Given this list of marker genes Tgfb1, Ccn2, Angpt2, Pdgfa, Igf1, Ptgs2 (prostaglandin-endoperoxide synthase 2), Hgf, Angpt1, here is a description of the gene set: from publication Galiè M, Konstantinidou G, Peroni D, Scambi I, Marchini C, Lisi V, Krampera M, Magnani P, Merigo F, Montani M, Boschi F, Marzola P, Orrù R, Farace P, Sbarbati A, Amici A (PMID 17998939) Tumor microenvironment in carcinomas recruits mesenchymal cells with an abnormal proangiogenic and invasive phenotype. It is not clear whether mesenchymal tumor cells (MTCs) derive from the activation of mature fibroblasts or from their stem cell precursors. However, stromal cell activation in tumors resembles in several aspects the mesenchymal rearrangement which normally occurs during reparative processes such as wound healing. Mesenchymal stem cells (MSCs) play a crucial role in developmental and reparative processes and have extraordinary proangiogenic potential, on the basis of which they are thought to show great promise for the treatment of ischemic disorders. Here, we show that MTCs have proangiogenic potential and that they share the transcriptional expression of the best-known proangiogenic factors with MSCs. We also found that MTCs and MSCs have the same molecular signature for stemness-related genes, and that when co-implanted with cancer cells in syngeneic animals MSCs determine early tumor appearance, probably by favoring the angiogenic switch. Our data (1) reveal crucial aspects of the proangiogenic phenotype of MTCs, (2) strongly suggest their stem origin and (3) signal the risk of therapeutic use of MSCs in tumor-promoting conditions. species: Mus musculus Mouse Gene Set: GALIE_TUMOR_ANGIOGENESIS Angiogenic genes up-regulated in A17 carcinomas (high vascularization) compared to the syngeneic BB1 and spontaneous tumors (little vascularization).